The following is a description of a gene set: Human Gene Set: MIR4512 species: Homo sapiens from publication Chen Y, Wang X (PMID 31504780) Genes predicted to be targets of miRBase v22 microRNA hsa-miR-4512 in miRDB v6.0 with MirTarget v4 prediction scores > 80 (high confidence targets)., and this is the list of marker genes: H2AX, MDGA2, MTCL3, MACIR (macrophage immunometabolism regulator), CAMKV, SNRPB, TMEM255A, ZNF584, ZNF521, MKNK1, PTPRD, NR2F2, UFM1, KIAA0408, SRPK1, GNG2, CNBP, USP2, SNRNP48 (small nuclear ribonucleoprotein U11/U12 subunit 48), H2AJ, GCC1, CWC22